Given this list of marker genes ALDH6A1, ACAD8, BCKDK, HIBCH, HIBADH, here is a description of the gene set: The chemical reactions and pathways resulting in the breakdown of valine, 2-amino-3-methylbutanoic acid. Human Gene Set: GOBP_VALINE_CATABOLIC_PROCESS species: Homo sapiens